The following is a description of a gene set: Mouse Gene Set: REACTOME_PTK6_REGULATES_RTKS_AND_THEIR_EFFECTORS_AKT1_AND_DOK1 studied in species Mus musculus PTK6 Regulates RTKs and Their Effectors AKT1 and DOK1, and this is the list of marker genes: Ptk6, Akt1, Ubb, Arap1, Uba52, Rps27a, Uba52rt, Ubc, Dok1, Cbl